The following is a description of a gene set: Human Gene Set: FARMER_BREAST_CANCER_CLUSTER_3 studied in species Homo sapiens Previous microarray studies on breast cancer identified multiple tumour classes, of which the most prominent, named luminal and basal, differ in expression of the oestrogen receptor alpha gene (ER). We report here the identification of a group of breast tumours with increased androgen signalling and a 'molecular apocrine' gene expression profile. Tumour samples from 49 patients with large operable or locally advanced breast cancers were tested on Affymetrix U133A gene expression microarrays. Principal components analysis and hierarchical clustering split the tumours into three groups: basal, luminal and a group we call molecular apocrine. All of the molecular apocrine tumours have strong apocrine features on histological examination (P=0.0002). The molecular apocrine group is androgen receptor (AR) positive and contains all of the ER-negative tumours outside the basal group. Kolmogorov-Smirnov testing indicates that oestrogen signalling is most active in the luminal group, and androgen signalling is most active in the molecular apocrine group. ERBB2 amplification is commoner in the molecular apocrine than the other groups. Genes that best split the three groups were identified by Wilcoxon test. Correlation of the average expression profile of these genes in our data with the expression profile of individual tumours in four published breast cancer studies suggest that molecular apocrine tumours represent 8-14% of tumours in these studies. Our data show that it is possible with microarray data to divide mammary tumour cells into three groups based on steroid receptor activity: luminal (ER+ AR+), basal (ER- AR-) and molecular apocrine (ER- AR+). Cluster 3: selected apocrine, basal and hypoxia genes clustered together across breast cancer samples. from publication Farmer P, Bonnefoi H, Becette V, Tubiana-Hulin M, Fumoleau P, Larsimont D, Macgrogan G, Bergh J, Cameron D, Goldstein D, Duss S, Nicoulaz AL, Brisken C, Fiche M, Delorenzi M, Iggo R (PMID 15897907), and this is the list of marker genes: VLDLR, PEX3, MALL, SRD5A1 (steroid 5 alpha-reductase 1), CLDN1 (NCBI Gene Id 9076), KYNU, SLC31A1, PALS2, ADM, EGFR, NDRG1, AGFG1, PDZK1IP1, NAMPT, STEAP3, ERO1A (endoplasmic reticulum oxidoreductase 1 alpha)